Given this list of marker genes Trp53, Zfp385a, here is a description of the gene set: studied in species Mus musculus part of: p53-Dependent G1 DNA Damage Response Reactome Pathway: Transcriptional activation of p53 responsive genes This event has been computationally inferred from an event that has been demonstrated in another species.<p>The inference is based on the homology mapping from PANTHER. Briefly, reactions for which all involved PhysicalEntities (in input, output and catalyst) have a mapped orthologue/paralogue (for complexes at least 75% of components must have a mapping) are inferred to the other species. electronically inferred by orthology from the curated human pathway